The following is a description of a gene set: A protein complex that plays a role in DNA double-strand break repair via nonhomologous end joining. Such complexes typically contain a specialized DNA ligase (e.g. Lig4 in eukaryotes) and one or more proteins that bind to DNA ends. studied in species Homo sapiens Human Gene Set: GOCC_NONHOMOLOGOUS_END_JOINING_COMPLEX, and this is the list of marker genes: NHEJ1, LIG4, ATP23, PRKDC, PAXX, XRCC4 (NCBI Gene Id 7518), DCLRE1C, XRCC5, XRCC6